The following is a description of a gene set: Mouse Gene Set: GOBP_POSITIVE_REGULATION_OF_INTERLEUKIN_18_PRODUCTION Any process that activates or increases the frequency, rate, or extent of interleukin-18 production. studied in species Mus musculus, and this is the list of marker genes: Tlr9, Dhx9, Casp1, Tnf, Tlr2, Nlrp9b, Gbp5, Usp50, Gsdmd